Given this list of marker genes Tfcp2l1, Tmsb15l, Ctso, Dennd5b, Kng1, Eefsec, Cd200, Podn, Ankrd17, Serpini1, Fbxo28, Luc7l3, Plpp7, Bub1, Ptbp1, Tnrc6a, Rnf181, Sema4f, Nhlh2, 4930523C07Rik, Slc16a5, Nr1d2, Ttc39c, Olfm1, Efna5, Pim3, Pla2g15, Purb, Nln, Tmsb15b2, Atp6v1d, 2310057M21Rik, Aktip, Mtf2, Dct, Mfsd6, Stx8, Klf4, Ybx3, Espl1, Arl8b, Baiap3, Cacna2d1, Edem3, Alg9, Gpn2, Sim2, Gpd1, Zmat3, Stk32b, Phgdh, Khdrbs2, Smarce1, Tenm3, Kng2, Sla, Oit3, Ndufs4, Klhl4, Gata2, Serpina7, Scoc, Adamts13, Pnpla6, Bach2 (BTB and CNC homology, basic leucine zipper transcription factor 2), Ctsc, Hip1, Taf9b, BC048679, Pofut1, here is a description of the gene set: species: Mus musculus Genes predicted to be targets of miRBase v22 microRNA mmu_miR_370_5p in miRDB v6.0 with MirTarget v4 prediction scores > 80 (high confidence targets). from publication Chen Y, Wang X (PMID 31504780) Mouse Gene Set: MIR_370_5P